Given this list of marker genes TFF3, MMP9, CHI3L1, LCN2, BPI, RGL4, ANXA3, CRISP3, DEFA3, S100A12, PGLYRP1, LTF, HP, CAMP, DEFA1B, S100P, CD177, CDA, here is a description of the gene set: from publication He P, Lim K, Sun D, Pett JP, Jeng Q, Polanski K, Dong Z, Bolt L, Richardson L, Mamanova L, Dabrowska M, Wilbrey-Clark A, Madissoon E, Tuong ZK, Dann E, Suo C, Goh I, Yoshida M, Nikolić MZ, Janes SM, He X, Barker RA, Teichmann SA, Marioni JC, Meyer KB, Rawlins EL (PMID 36493756) studied in species Homo sapiens Human Gene Set: HE_LIM_SUN_FETAL_LUNG_C2_MYELOCYTE_LIKE_CELL Myelocyte-like